Given this list of marker genes Cbr3, Gatd1, Nqo2, Glo1, Hagh, Aldh8a1, Pnkd, Hsd17b6, Haghl, Cyp4f40, Kyat1, Kynu, Park7, Oxct1, Kyat3, Akr1c18, here is a description of the gene set: Mouse Gene Set: GOBP_KETONE_CATABOLIC_PROCESS species: Mus musculus The chemical reactions and pathways resulting in the breakdown of ketones, a class of organic compounds that contain the carbonyl group, CO, and in which the carbonyl group is bonded only to carbon atoms. The general formula for a ketone is RCOR, where R and R are alkyl or aryl groups.